The following is a description of a gene set: Genes up-regulated in monocyte-derived dendritic cells: untreated versus LPS (3h). Human Gene Set: GSE4748_CTRL_VS_LPS_STIM_DC_3H_UP from publication Macagno A, Molteni M, Rinaldi A, Bertoni F, Lanzavecchia A, Rossetti C, Sallusto F (PMID 16717116) species: Homo sapiens A cyanobacterial LPS antagonist prevents endotoxin shock and blocks sustained TLR4 stimulation required for cytokine expression. We report the identification and biologic characterization of an LPS-like molecule extracted from the cyanobacterium Oscillatoria Planktothrix FP1 (CyP)., and this is the list of marker genes: CREB3L1, RRAGA, IL1RL1, SAV1, ANGPTL2, ZNF532, SUFU, BICC1, RIPK1, LIFR, HECTD1, MX1, SERTAD3, AKAP12, PIK3R4, DIP2B, KLK6, ELK3, GPR153, FAM32A, PDGFRA, DYNC1I2, TLL1, PTCH1, EDN1, MMP13, RBM5, SLC38A2, RIN2, ENC1, GHR, GAS1, RND3, AHNAK, POLR2A, EREG, RTP4, ARL2BP, MT2A, STX5, DKK3, C1QTNF1, IRF4, NCAM1 (NCBI Gene Id 4684), TEAD3, CGGBP1, POSTN, MED1, MITD1, TUBA3C, CTDSP2, RPS6KC1, E2F8, FRMD6, CAB39, ZFP90, ANTXR2, SERPINE1, SCARA5, KCTD11, SMAD7, MAN1A1, PTGR3, NEDD9 (NCBI Gene Id 4739), CYP1B1, HNRNPD, PTPN11, ARHGEF10, ZNF292, SLC16A3, CDC123, OXR1, TUT1, OXSR1, MBTPS1, SOX2, FBXL14, INHBA, RAP2A, WASF2, UNC5B, CDH11, SLC25A37, CD248, BHLHE22, MT1E, RHOJ, HBEGF, ASXL1, TERF1, RLF, CCN1, TRIM2, TMEM35A, ITGAV, IL13RA2, IGFBP3, UBE2Z, SCAF11, MOB1B, KDM3B, PRSS23, FSTL1, COL5A2, NAB2, SPRED2, EDEM1, GTF2B, IFI35, TUT7, HMGA2, WNT5A, DPYSL3, LRRC58 (NCBI Gene Id 116064), IFIT3 (interferon induced protein with tetratricopeptide repeats 3), IARS1, OTUD4, NFATC2IP, NMD3, HS6ST2, AMFR, SEC23A, TSR3, ANKRD17, ACKR3, PGF, BLTP2, PENK, IRGM, MLXIP, TSPAN5, MORF4L2, KLHL22, HAS2, PSD3, BCL2L11, MMP10, SERPING1, SIN3A (SIN3 transcription regulator family member A), CACNA1H, CAV1, SUPT16H, PYGL, AMPD3, AGAP1, CRY2, IFIT1B, FZD7, TRIB2, CNOT1, CCNC, ERRFI1, PDK1, GALR2, TIMP3, FBXL20, SPRED1 (NCBI Gene Id 161742), FNDC3A, ADAMTS1, MAML1, SNX4, MAGEE1, COL3A1, M1AP, ANGPTL4, TARS1, CMAS, SESN2, UBQLN2, RESF1, SYNPO, FBN1, STARD13, IQGAP1, RASSF8, NPR3, PGP, IFI44, PDE6H, MIS12, RAPGEF1, EMP1, ZNF334, INTS5, NID1 (NCBI Gene Id 4811), AMMECR1, CCN2, RBM10, SOX9, EGR2, FEM1B, FUS, UFD1, TWF1, RNF19A, LRBA, CXCL12, AMOTL2, SLC14A1, NTMT1